Given this list of marker genes Atf2, Smo, Dach1, Cdhr2 (NCBI Gene Id 639588), Srpx, Pak1, Fap, Tspo, here is a description of the gene set: Mouse Gene Set: GOBP_DETECTION_OF_CELL_DENSITY The series of events in which information about the density of cells in a population is received and converted into a molecular signal. species: Mus musculus